Given this list of marker genes ATRN, UBE3A, WAC, EIF4G2, RWDD2A, HNRNPD, AKAP5, CSMD1, PLXNC1, SHMT1, UBA6, TENT4B, ANK3, VIPR2, CRTAM, HIVEP3, ZFP1, RBL1, APOL6, ISX, CACNA2D1, SORBS2, MDGA2, SACM1L, LCLAT1, PDE3A, CPSF6, NCEH1, NR2C2, AMPH, LHX8 (NCBI Gene Id 431707), BCL7A, LCOR, JADE1, AUTS2, PTPRM, TRIM63, STAT5B, USP9X, WWP1, FOXD4, OSM, CCDC9B (coiled-coil domain containing 9B), UVSSA, SCN3A, KDELR2, ELK4, SCN1A, HIPK1, LPGAT1, ARRDC2, MARK3, PRKACB, FOXD4L3, GRIP1, RUNX1, ASH1L, EPC2, SPTBN4, FLT1, MED13L, RASSF5, KMT5B, PLXNA4, NELL2, TAOK1, UBE2K, TNPO1, RALA, ARHGAP28, UNKL, SPECC1, ZDHHC17, TASOR, DMRTC1, RPS6KB1, DFFB, PF4, BICD2, SLC1A2, TRIP13, EEF2KMT, ADAM10, GRIK2, FAM43A, XRCC4 (NCBI Gene Id 7518), POLR1D, PCDH19, CDC42EP3, KRBOX4, GATM, TRMT9B, ATXN7, PNN, MTDH (NCBI Gene Id 92140), GLRA3, TET1, RIMS2, SYT14, PTBP1, GGNBP2, SNAI2, CCDC6, NWD2, HOMER1 (homer scaffold protein 1), CNKSR2, AGPAT5, SLITRK4, ATP11C, GMFB, RGMB (repulsive guidance molecule BMP co-receptor b), TMEM245, ADAM19, LCN10, VOPP1, SCYL2, DYRK1A, FOXN3, DPH3, AGFG1, RALBP1, RARG, PPP1R3D, MRPS33, PDS5A, ZBTB5, SGMS1 (NCBI Gene Id 93538), AADAT, REV3L, NMT2, MOB1B, CUL4A, SYT11, SCLT1, GP6, CASP7, AGAP1, LRRN1, ZSWIM6, MBNL3, ERC2, ELK3, PTPRD, GTF2H1, CTNNA2, PIWIL4, THAP6, TLCD4, NPAT, OXTR (NCBI Gene Id 5021), CNTNAP3, SLC17A6, FLRT3, NUDT16, IRF2BPL, HACL1, SUN2, PPHLN1, ZNF85, KPNA1, CAMK4 (calcium/calmodulin dependent protein kinase IV), PJA2, FST, SEMA6D, MAP4, CHMP2B, BCL11A, NUP43, NEDD1, DENND1B, RBMS3 (RNA binding motif single stranded interacting protein 3), PRKCE, FGFBP3, GRP, UBN2, C3orf80, KCTD1, AGO3, EOGT, HOXB5, E2F7, BCL2, UNC13A, DTL, SP3, TFRC (transferrin receptor), BRWD3, ENDOD1, PGRMC1, ANKRD12, SECISBP2L, KIAA0753, SLC4A7, PCLO (piccolo presynaptic cytomatrix protein), PRDM1, CXCR6, ATP1B1, RAB22A, KHDRBS3, BCL11B, CGGBP1, MS4A13, ADAM17, PDE6C, SGCD, PNPT1, LACTB, NEFL, LIMS1, RFX7, DAB2IP, DMRT2, RPL28, PLCB4, MACO1, BPTF, CCDC93, PAX6, DMRTC1B (NCBI Gene Id 728656), AKIRIN1, OLIG3, SNTB2, CAMTA1, RB1, ZNF440, PCDH9, C14orf28, ARHGEF3, C19orf44, XPO4, ALPI, CBX4, ARID1A, AMN1, LUM, DHRS12, CLOCK, MLLT11, OLFML2B, BACH2 (BTB domain and CNC homolog 2), CNOT7, SENP7, RBPJ, CLCN4, TRPM1, C2orf74, MTF1, KIAA0232, ZNF268, APC, DKK2 (dickkopf WNT signaling pathway inhibitor 2), PDE10A, NEXMIF, SNX13, GEM, PABPC1, CUL1, MEIS1, FCRL3, TSPYL4, CHRNA3, ZER1, KCNN3, POGLUT3, here is a description of the gene set: Human Gene Set: MIR507 from publication Chen Y, Wang X (PMID 31504780) studied in species Homo sapiens Genes predicted to be targets of miRBase v22 microRNA hsa-miR-507 in miRDB v6.0 with MirTarget v4 prediction scores > 80 (high confidence targets).